The following is a description of a gene set: species: Homo sapiens Pathway Definition from KEGG: LMP1 -> (TRAF3,TRAF5) -> PI3K EBV LMP1 to PI3K signaling pathway. Pathway ID: N00485. Pathway type: Pathogen. Pathway class: nt06530 PI3K signaling. Human Gene Set: KEGG_MEDICUS_PATHOGEN_EBV_LMP1_TO_PI3K_SIGNALING_PATHWAY, and this is the list of marker genes: TRAF3, TRAF5, PIK3CA, PIK3CD, PIK3CB